Given this list of marker genes ERCC5, POLR2I, XAB2, ERCC3, USP7, ERCC2, ERCC6, ELOF1, ERCC8, HMGN1, UVSSA, RBX1, here is a description of the gene set: Human Gene Set: GOBP_TRANSCRIPTION_COUPLED_NUCLEOTIDE_EXCISION_REPAIR The nucleotide-excision repair process that carries out preferential repair of DNA lesions on the actively transcribed strand of the DNA duplex. In addition, the transcription-coupled nucleotide-excision repair pathway is required for the recognition and repair of a small subset of lesions that are not recognized by the global genome nucleotide excision repair pathway. studied in species Homo sapiens